Given this list of marker genes Il23a, Itgb3 (integrin beta 3), Ninj1, Ccr1, Ppp3ca, Pik3r1, Csf1r, Pou4f1, Gpr68, Il17a, Ubash3b, Ifng, Pira12, Tnfsf11, Cartpt, Cldn18, Il12b, Iapp, Fshr, Pilrb1, Notch2, Zbtb7a, Pias3, Ctnnb1, Traf6, Mafb, Inpp5d, Rptor, Clec2d, Gsk3b, Tjp2, Gnas, Nedd9, Tnfrsf11b, Fshb, Nf1, Pou4f2, Prxl2a, Clec2i, Creb1, Slc9b2, Gpr55, Car2, Tcta, Eeig1, Adam8, Fos, Erfe, Pira1, Tmem64, Ccl9, Ltf, Ocstamp (osteoclast stimulatory transmembrane protein), Esrra, Tyrobp, Fbxw7, Tmem178, Ceacam1, Ccr1l1, Lrrc17 (leucine rich repeat containing 17), Gpr137, Ppargc1b, Lilrb4a, Fstl3, Tnfaip6, Clec2g, Csf1, Rassf2, Il20, Tfe3, Klf10, Tnf, Il4, Fgfr3, Mtor, Tnfrsf11a, Cebpb, Dlk1 (NCBI Gene Id 13386), Trem2, Apc, Ccl3, Mitf, Ccl5, Asxl2, Gpr137b (G protein-coupled receptor 137B), Inpp4b, Sfrp1, Tob2, Lilrb4b, Fbn1, Ifnb1, here is a description of the gene set: Mouse Gene Set: GOBP_REGULATION_OF_OSTEOCLAST_DIFFERENTIATION Any process that modulates the frequency, rate or extent of osteoclast differentiation. studied in species Mus musculus